The following is a description of a gene set: Human Gene Set: MODULE_317 species: Homo sapiens Genes in the cancer module 317., and this is the list of marker genes: TNFRSF13C, NCOA7, PTGS2, GRAPL-AS1, IPCEF1, TRIM7, NECAP2, EPS15L1, FUCA1, POLDIP3, DZIP3, TIMP4, AURKAIP1 (NCBI Gene Id 54998), ACSL1, ATRN, MRPL27, SFRP1, TDP1, POGLUT2, PI4K2B, GSN, CYYR1, ZGRF1, NUP54, CSF2RB, OTOR, SURF6, DCANP1, ACKR1, GPSM3, FN1, CSF1, PIF1, CD8A, NGF, TMLHE, NELFB, CST1, PGLYRP2, CBLN1, MRPL47, BCL2L14, CDH4, PRPF39, PDCD2L, CCBE1, CCL11, MXRA8, CDH5, PKIA, FOS, DHODH, BEGAIN, SLC22A3, KATNAL1, TBC1D9, GPATCH3, NRL, PTX3, PDE4D, PTPRF, KATNIP, CCAR2, EPHB6, CHD1, MAPK4, DYNC2LI1, HMGN5, MORC3, TOR4A, ATG16L1, AMOTL2, ZNF107, MRPL36, OXGR1, CHD9, ADIPOR2, RNF213, FABP2, WRNIP1, FNBP4, HOMER2, SLC11A2, SH2B3, FGFR1, ZNF318, PITPNC1, PLEKHM2, GABPB1-IT1, FMN1, CXCL10, SV2B, NR2E1 (NCBI Gene Id 7101), MYL12A, FURIN, ACSM5, EPHA7, TMEM97, WDR25, LYL1, NEIL1, ATG4D, PAPOLA, GJA5, MPRIP, HACD1, ITM2C, COPE, TIMELESS, PDCD6, MCMBP, CD1D, OBSCN, ARID5A, TMEM250, ACE, LRRC19, CUL9, WDR46, LY9 (lymphocyte antigen 9), DNAAF4, DIO3, BGN, HNRNPDL, PYGB, DIRAS2, SAV1, IL1RL1, BCR, ARHGAP45, AMY2B (amylase alpha 2B), EEF1D, MMP9, FBXO11, ZDHHC2, GEM, ANKRD13A, NHSL3, NELFCD, BCL2L13, FAM169A, ERVMER34-1, PLEKHF2, TMEM120A, CCDC81, PCGF1, TMED3, DCLK1, CNOT6L, TMEM161A, GPR26, DPYD, DNAJA1P5, TSLP, GSTM1, ZNF143, AASS, EYA3, TUBA4A, KDM4D, DCTN3, GOLGA4, MRPL18, NADSYN1, NME1, LRP3, ZCCHC4, LY86, LRRC14, ATG2A, ALKBH4, CD1A, BSDC1, PHAX, DNAH11, MED25, CHST1, RPAP3, SLAMF7, LYZ, COCH, ZMAT4, FPR2, PLEKHG1, OR7E12P, RRAGD, OR2A1, WDR19, IL18R1 (NCBI Gene Id 8809), PNMA8A, TBC1D8B, SIAH1, PPP4R2, CLCF1, ERLIN2, MRPS15 (NCBI Gene Id 64960), SPSB4, PCED1B, CEP162, C19orf73, ACVR1, PTPRZ1, RBM7, KCNE4, QSER1, KDM5B, TMEM255A, CACNA2D3, ABI3, TMEM47 (NCBI Gene Id 83604), EPCIP, EIF2B4, SMG7, CEBPZ, XPO4, SQOR, REPIN1, KLHL36, ITGAM, MLYCD (malonyl-CoA decarboxylase), LARP1, ART3, ESPN, AMZ2, ABHD17C, ASXL2, C1orf116, TMEM62, NOP53, CMTM6, DDX60, VNN1, COQ8A, PIP4K2C, NUP58, GJC2, ZBTB5, ISYNA1, COL6A3, SARAF, LRRC4C, EPB41L4B, BAG3, USP36, TTF2, ZFP41, FGD6, SPNS1, LEPROTL1, LAP3, CDK16, LMTK3, NACAD, BTN2A1, ELOB, SLMAP, C17orf75, KLHL41, LNPK, LDAH, SLC25A27, ILRUN, FLJ13224, LRRN3, CELF2, STAMBPL1, EARS2, HS1BP3, CCDC85C, HIVEP2, GEMIN7, PAQR5, AGAP2, TLN1, CDK11A, SLC19A1, MAPKBP1, ERMN, TP53, RNF103 (NCBI Gene Id 7844), FAIM, PAWR, PPP1R14D, TMEM144, STAT3, SCARA3, FBXW4, GLB1L (NCBI Gene Id 79411), TAL1, CHST9, UFSP2, UNC79, SENP1, SNX5, NANS, CCDC134, HIF1A, DEXI, CORIN, IL1A, ARHGAP15, SOX6, GOLGA5, MST1R, LANCL2, ELAC1, PARS2, PYCR3 (pyrroline-5-carboxylate reductase 3), CELP, EFCC1, DCAF15, PTPRT, UGCG (UDP-glucose ceramide glucosyltransferase), MICALL1, GJA1, TRIM14, FAF1, MED28, ACTR6, FAR2, PLGLB2, NCF2, CCL2, YWHAB, MMP7, NUTM2F, INIP, BAIAP3, ANKFY1, HBE1, SMAD3, GPR68, KAT2B, NSUN3, SP140L, BRAP, BASP1, KRT19, MCTS1, CLUH, REV3L, SIPA1L3, S100A5, TRABD, MREG, RPRM, SDC3, KIAA2013, SSBP4, SLC43A1, XRN2 (5'-3' exoribonuclease 2), RERE, TRIM48 (tripartite motif containing 48), STRIP2, ITGA4, MBD5, ATXN7 (NCBI Gene Id 6314), PRDM1, NXPH4, LACTB, NOL7, TFPI2, MICB, CHL1, KLHL4, ANXA1, NFIL3, APTX, SEMA4A, CTSZ, ARG1, CYP2A7, MAL2 (mal, T cell differentiation protein 2), CIP2A, AKAP8L, MAGED4B, MOB4, PRDM8, CYP1A1, BFSP2-AS1, MAP2K6, NEPRO (NCBI Gene Id 285338), ZNF566, MOCOS, IL1R2, CCNL1, INO80B, MTMR12, CD163, UTP11 (UTP11 small subunit processome component), FAM220A, STRN, SUGP2, SLC26A8, ITGB1, OSBPL9, SLITRK1, CCDC90B (coiled-coil domain containing 90B), SNRNP25, RNF220, CXCL8, AHNAK, VIT, TMCC2, CITED2, ELOVL2 (NCBI Gene Id 54898), ITGB5 (integrin subunit beta 5), ZNF264, PHIP (NCBI Gene Id 83843), TESPA1, DLC1, TMEM121B, SLC17A8, TMEM248, ARHGAP20, TMT1A, MED12L, EREG, BRIP1, BPIFA1, ALG6, AMIGO1, RNASEL, ZMYM5, POU6F2 (NCBI Gene Id 7968), ATP8A2, PORCN, LINC00160, SCD, DES, MFSD1, RNASE6, ITK, ZKSCAN7, MMP14 (matrix metallopeptidase 14), QKI, CDH22, TNFSF4, ZNF117, SPMAP2, CAND1